The following is a description of a gene set: species: Mus musculus Mouse Gene Set: GOCC_CANONICAL_INFLAMMASOME_COMPLEX A cytosolic protein complex that is capable of activating caspase-1., and this is the list of marker genes: Nlrp1b, Nlrp9a, Nlrp1a, Naip1, Casp12, Gsdmd, Pycard, Aim2, Naip5, Nlrp6, Nlrp3, Naip6, Nlrp9c, Nlrp9b, Naip2, Nlrc4, Dhx33, Mefv, Ddx3x, Casp1, Casp4